Given this list of marker genes CLTC, TRAK1, TENM2, TNKS2, FOXL1, MEF2C, DYM, NPAS3, PCDHB12, UBE2Q2P13, TFEC, ATOH7, NQO1, DYNC1I1, SIRPA, ILDR2, CDYL2, RBMS1, ZNF621, CREB1, PBX1, ZCCHC2, MYCN, ZC3HC1, SHROOM3 (NCBI Gene Id 57619), MRE11, MTHFSD, TMED2, SCN8A, CXCR1, GABARAPL2, XK, GPRASP3, SON (SON DNA and RNA binding protein), CLRN1, JPH3, AKIRIN1, NFIX, RALA, ARID1A, ZNF827, DDX17, PCSK9, NSUN7, WRNIP1, FDFT1, UPF1, GSTCD, RGS8, SMURF1, VPS35, SCEL, SOX30, IL20RA, RB1, CDC25A, LYPD1, DNAJA1, SPCS2, SERAC1, SH3BP5L, MRPL33, ADAM23, TEX261, CMTR1, KDM7A (lysine demethylase 7A), RCAN2, GSDME, MGAT3, SMG7, SOX1, DPP10 (dipeptidyl peptidase like 10), ZRANB1, SMIM10L1, here is a description of the gene set: Human Gene Set: MIR1295B_5P Genes predicted to be targets of miRBase v22 microRNA hsa-miR-1295b-5p in miRDB v6.0 with MirTarget v4 prediction scores > 80 (high confidence targets). from publication Chen Y, Wang X (PMID 31504780) studied in species Homo sapiens